Given this list of marker genes Cela2a, Mpo, Ncf4, Lrrc25, Cma1, Ngp, Gfi1, Lyz2, Vpreb1a, Tpsab1 (tryptase alpha/beta 1), Csf1r, Pglyrp1, Ctsg, Btk, Ncf2, Gfi1b, Csf3r, Mcpt8 (NCBI Gene Id 17231), Camp, Itgam, Csf2ra, Pirb (paired Ig-like receptor B), Clec10a, Itgb2l, Treml1, Stom, Trem3, Trem2, Matk, Ccl6, here is a description of the gene set: studied in species Mus musculus Mouse Gene Set: VILIMAS_NOTCH1_TARGETS_DN T-cell acute lymphoblastic leukemia (T-ALL), unlike other ALL types, is only infrequently associated with chromosomal aberrations, but it was recently shown that most individuals with T-ALL carry activating mutations in the NOTCH1 gene. However, the signaling pathways and target genes responsible for Notch1-induced neoplastic transformation remain undefined. We report here that constitutively active Notch1 activates the NF-kappaB pathway transcriptionally and via the IkappaB kinase (IKK) complex, thereby causing increased expression of several well characterized target genes of NF-kappaB in bone marrow hematopoietic stem cells and progenitors. Our observations demonstrate that the NF-kappaB pathway is highly active in established human T-ALL and that inhibition of the pathway can efficiently restrict tumor growth both in vitro and in vivo. These findings identify NF-kappaB as one of the major mediators of Notch1-induced transformation and suggest that the NF-kappaB pathway is a potential target of future therapies of T-ALL. Genes down-regulated in bone marrow progenitors by constitutively active NOTCH1. from publication Vilimas T, Mascarenhas J, Palomero T, Mandal M, Buonamici S, Meng F, Thompson B, Spaulding C, Macaroun S, Alegre ML, Kee BL, Ferrando A, Miele L, Aifantis I (PMID 17173050)